Given this list of marker genes Qng1, Dnph1, Pgm2, Adk, Pnp, Aprt, Hprt1, Dctd, Mtap, here is a description of the gene set: Mouse Gene Set: GOBP_NUCLEOSIDE_SALVAGE studied in species Mus musculus Any process which produces a nucleotide, a nucleobase linked to either beta-D-ribofuranose (ribonucleoside) or 2-deoxy-beta-D-ribofuranose (a deoxyribonucleotide), from derivatives of it without de novo synthesis.